The following is a description of a gene set: studied in species Homo sapiens Spastic paralysis affecting all four limbs. Spastic tetraplegia Human Gene Set: HP_SPASTIC_TETRAPLEGIA, and this is the list of marker genes: COL4A2, GRIA4, RNASEH2B, ANKLE2, OSTM1, AP4M1, TUBB3, AP4E1, IBA57, PPIL1, PIGA, ADGRG1, ARSA, CNPY3, GLB1, NDUFAF4 (NADH:ubiquinone oxidoreductase complex assembly factor 4), KIF5C, RNASEH2A, DENND5A, ATP13A2, STXBP1, ALS2, CNP, PPFIBP1, PRDM8, DPH5, SRPX2, PLA2G6, ARX, NDUFAF5, CACNA1D, ELOVL4, NDE1, MCOLN1, GSX2, TUBG1, RNU7-1, PHGDH, TMX2, AFG2B, CLN8, KIF2A, GLYCTK, MOCS2, SPTBN1, MOCS1, LSM11, NFU1 (NFU1 iron-sulfur cluster scaffold), SIX6, DYNC1H1, GOT2, PI4KA, PSMC1, CSF1R, TANGO2, IFIH1, TBCE, COLGALT1, KCNC2, MTFMT, EXOC2, SHMT2, AUH, SPTAN1, RANBP2, CYB5R3, ATP6V0A1, SAMHD1, ADAR, GRIN1, WDR45B, CACNA1E, OTUD6B, CDC40, RNASEH2C, KANK1, UNC80, PRDM13, MECP2, CTNNA2, H4C5, HSD17B10, RAB18, PDHX (NCBI Gene Id 8050), WDR73, SDHAF1, NAXD, KARS1, SOX2, MRPS22, DEGS1, TUBA1A, COASY, TREX1, SCN3A, BCL11B, NALCN, PCDH12, SYNJ1, TBC1D20, SHQ1, WARS2, SLC19A3, SCN2A, SEC31A, SLC1A4, ASNS (NCBI Gene Id 440), PET100, CYB5A (NCBI Gene Id 1528), YIF1B, COG2, VPS53, CLIC2, SLC16A2, LIAS, MINPP1, FUCA1, SOX10, DTYMK, SEPSECS, ADD3, APC2